Given this list of marker genes Jakmip1, Ldb2, 4930405L22Rik, Gm16223, Wdr1, Bod1l, Fgfbp1, Prom1, Gm7205, Gm36017, Grpel1, Drd5, Gm25377, 1600023N17Rik, Lcorl, Zbtb49, Lap3, 4930518C09Rik, Clnk, 4930421P07Rik, 9630001P10Rik, D5Ertd579e, 2900064K03Rik, Clrn2, Gm10048, C030015E24Rik, 4930421C12Rik, Gm29036, Nkx3-2, Man2b2, Ppp2r2c, 4930448I18Rik (NCBI Gene Id 73965), Gm20052, Gm43700, Wfs1, Gm26560, Ccdc96, Gm2810, Otop1, Htra3, Gm43699, 4930513D17Rik, Gm5292, Kcnip4, Gm3010, Gm3364, C1qtnf7, Gm7882, Afap1, Fbxl5, Ppihl (NCBI Gene Id 676493), Slit2, Tmem128, Hs3st1, Trmt44, Gm19031, Clnkos, Tapt1, 4930431F12Rik, Msx1, Tbc1d14, Cpeb2, 4930449I04Rik, 4930519E07Rik, 4931431C16Rik, 2210406O10Rik, Stk32b, Evc, Mrfap1, Gm7931, Gm7854, Mir218-1, Fam184b, Gm23022, Gm15732, Crmp1, Bloc1s4, 8030487O14Rik, E030026E10Rik, Gm43093, Gm40293, Mir7689, Rab28, Cytl1, Ncapg, Ppp2r2cos, Gm36401, Gm16015, Gm40289, Psapl1, Gm5865, Gm35191, Med28, Gm22779, Gm19932, 6030400A10Rik, Gm42427, Sh3tc1, Slc2a9, Gm15866, Gm5555, Gm4754, Gm43367, Gm17824, Ablim2, Gm40292, Tada2b, Lyar, Nsg1, Stx18, Bst1, Gm25767, Gm24878, Adgra3, Gm7816, Gm5554, Gm16401, 5730480H06Rik, Gm42935, D5Ertd615e, H2af-ps1, Acox3, E430021H15Rik, Mir6414, Gm40318, Gm15796, Cc2d2a, Mir8117, Gm7988, Gm20156, Gm22249, Evc2, Qdpr, Cd38, Gm5291, Gm1043, Gm7181, Sorcs2, 4930487D11Rik, Gm5298, Zfp518b, here is a description of the gene set: Mouse Gene Set: chr5B3 studied in species Mus musculus